The following is a description of a gene set: Human Gene Set: GOBP_REGULATION_OF_MITOCHONDRIAL_FISSION species: Homo sapiens Any process that modulates the rate, frequency or extent of mitochondrial fission. Mitochondrial fission is the division of a mitochondrion within a cell to form two or more separate mitochondrial compartments., and this is the list of marker genes: STAT2, PRKN, PGAM5, RALBP1, DNM1L (dynamin 1 like), SPIRE1, LRRK2, KDR, RALA (RAS like proto-oncogene A), IRGM, PINK1, MIEF1, MIEF2, PPARG, AURKA, MFF, C11orf65, FIS1, DDHD1, INF2, MAPT, MARCHF5, MYO19, TMEM135, BNIP3, MUL1, DDHD2, DCN, MCU, CYRIB, VPS35 (VPS35 retromer complex component)